The following is a description of a gene set: Expression of estrogen-related receptor alpha (ERRalpha) has recently been shown to carry negative prognostic significance in breast and ovarian cancers. The specific role of this orphan nuclear receptor in tumor growth and progression, however, is yet to be fully understood. The significant homology between estrogen receptor alpha (ERalpha) and ERRalpha initially suggested that these receptors may have similar transcriptional targets. Using the well-characterized ERalpha-positive MCF-7 breast cancer cell line, we sought to gain a genome-wide picture of ERalpha-ERRalpha cross-talk using an unbiased microarray approach. In addition to generating a host of novel ERRalpha target genes, this study yielded the surprising result that most ERRalpha-regulated genes are unrelated to estrogen signaling. The relatively small number of genes regulated by both ERalpha and ERRalpha led us to expand our study to the more aggressive and less clinically treatable ERalpha-negative class of breast cancers. In this setting, we found that ERRalpha expression is required for the basal level of expression of many known and novel ERRalpha target genes. Introduction of a small interfering RNA directed to ERRalpha into the highly aggressive breast carcinoma MDA-MB-231 cell line dramatically reduced the migratory potential of these cells. Although stable knockdown of ERRalpha expression in MDA-MB-231 cells had no effect on in vitro cell proliferation, a significant reduction of tumor growth rate was observed when these cells were implanted as xenografts. Our results confirm a role for ERRalpha in breast cancer growth and highlight it as a potential therapeutic target for estrogen receptor-negative breast cancer. from publication Stein RA, Chang CY, Kazmin DA, Way J, Schroeder T, Wergin M, Dewhirst MW, McDonnell DP (PMID 18974123) Human Gene Set: STEIN_ESRRA_TARGETS Genes regulated by ESRRA in MCF-7 cells (breast cancer). species: Homo sapiens, and this is the list of marker genes: MGST3, IDH3B, NPM3, RABIF, SOD2, SLC35F2, PLCXD1, DLD, RAP1GAP2 (NCBI Gene Id 388321), HPN, ATP5MG, CSNK1G2, ECI2, MRPS11, TCAF1, CTSC, CDC23, GMCL1, OXA1L, OSBPL1A, WWC1, PCTP, GFPT1, KIF3B, HTATIP2, PLEKHB2, NDUFA9, NDRG2, OGDH, NAGPA, TBX2 (NCBI Gene Id 6909), SUCLA2, RGP1, MIEF1, BDH2, MTX2, TIMM50, SULT2B1, TACC1, ATP2A3, KCNN4, RHOQ, MRPL4, RNF34, EXOSC2, DBNDD1, ASB6, SEC23B, RASA4, NDUFS1, GFPT2, UST, PPIC, ST3GAL4, CAV2, MAEA, RBM38, VPS26C, ANKRD28, TMEM184C, ACO2, IMMT, HMOX2, ABCB9, FRK, MFF, TRPC3, TNFRSF11B, MFN2, PRKAR2B, AURKA, PDHX, HLA-E, NANS, STN1, SMC2, RAB35, MINDY1, SLCO1A2, DGUOK, PXMP4, LEFTY1 (NCBI Gene Id 10637), H2BC10, UQCRFS1, PLA2G12A (phospholipase A2 group XIIA), TBC1D31, EFCAB14, FAM174B, QRSL1, COX7B, CYTH1, NPR3, NXF1, CCNG2, VWA8, ATP5MC1, EPAS1 (endothelial PAS domain protein 1), ACAA2, NDUFS2, SDHB, IFT27, PLPPR2, HIGD1A, EGLN1, CYCS, NOL6, PDSS1 (decaprenyl diphosphate synthase subunit 1), CASP9, GK, ETS2, KCNK13, DGAT1, CTSL, NDUFA8, MARCHF3, FAHD2A, SEPTIN8, ATP5PO, KIAA0040, DAXX, MARCKS (myristoylated alanine rich protein kinase C substrate), CKMT2, NDUFS8, ZNF302, CLDN3, TRAK2, FANCF, ST3GAL5, ACAT1, MYO19, EBP, CKMT1B, DHDDS, GRK4, DLAT, ZNF24, ACACB (NCBI Gene Id 32, acetyl-CoA carboxylase beta), NDUFS4, CYBC1, FOXD1, TMX4, FOXC1, KANK2, PLGRKT, VEGFA (NCBI Gene Id 7422), ATP5MC3, UGP2, SUCLG1, CKB, UQCRB, VDAC3, ADRA2C, CYP1B1 (cytochrome P450 family 1 subfamily B member 1), OPA1, MBD4, SLC25A12, IVNS1ABP, TRIM8, DCTPP1, CYP1A1, WDHD1, SIK1, AFG3L2, HOOK1, NDRG4, TGFBR2, COQ3, ADCY1, ECSIT, SAMM50, ATG2B, TRAM2, TCIRG1, INPP1, YIPF2 (Yip1 domain family member 2), PGM1 (NCBI Gene Id 5236), AHCYL1, ACYP1, TNFRSF10B, BMP7, HCCS, SNX24, CYP24A1, SCAMP5, SLC38A7, TUBD1, SLC46A3, RALA, FZD2, MTARC2, CA12, TOMM70, FDX1, STX18, BRD3OS, PCGF1 (polycomb group ring finger 1), EPN3, IMPA1, PATZ1, PPP2R2D, TMC6, SETMAR, PHB1, SOCS2, RGS19, ZHX3, ATP6V0E2, FSCN1, GOT2, ZNF669, TACO1, AHCYL2, ATP5MJ, INTS12, SLC10A2, CXCL12, SYNGR1, SLC25A20, CFLAR, VDR, FAM162A, THAP4, YJU2B, COX5B, FA2H, ZNF7, CAAP1, ATP5PF, RAP1GAP, B4GAT1, CD83, RBM7, ASPSCR1, MTRF1, AKAP1, PDCD10, TFE3, TRMT112, PRPSAP1, UQCRC2, FZD10, SSB, RNF139, APOO, SLC16A1 (NCBI Gene Id 6566), RAB21, UCK2, BRD3, JMJD6, LPCAT3, MMACHC, ZNF576, MYO6, TUBB6, SUPV3L1, DFFA, USP4, SPTLC2, RNF14, TIMM8A (NCBI Gene Id 84782), MRPS30, IQSEC1, GAS6, RAB17, STK26 (serine/threonine kinase 26), ST6GALNAC4, AIFM1, NDUFS3, CS, FDXR, ELP5, DUSP1, NSUN3, NQO2, HEXIM1, TMEM132A, ISCA1, GRPEL1, PAFAH2, GSTM1, ZBTB43, TRIM52, UTP25, ZNF750, SEC14L2, MRPS22, GDF15, MCF2L-AS1, HSPB8, RBM12B, AK1, IDH3A, RHBDF1, CEP70, RBFOX2, FAM50B, ATP5F1C, IER3, FGFR3, LIFR, MDH1, TIMM17A, ARID4A, CENPU, TACC2, MORC2, SPINT1, MED9, FBXL15, ZNF768, SMIM8, ZNF134, DNAJC11, SLC25A3 (NCBI Gene Id 5250), ZNF514, CCDC121, RHOF, NECAB3, CALU, CPT1A, MMUT, MXD4, DENND10P1, NR2F2 (nuclear receptor subfamily 2 group F member 2), TERF1, TNFAIP8, ANXA2P3, CIAPIN1 (NCBI Gene Id 57039), ATP1B1, MPC2, NFU1, HPF1, ASNS, SIGMAR1, ABCB7, OCLNP1, QARS1, RTL8C, SLC16A3, PEA15, UBAC1, MLYCD, CISD1, MAFB, COX10, CHCHD3, ORC2, SLC37A4, CLEC16A, MGST2, FASTKD1, PCYT2, MANF, DDIT3, PPP1R13L, P2RX5, DECR1, ARFRP1, PFKM, CAPRIN2, TRIM14, SMARCC1, TIGAR, NDUFB5, RFXANK, RNASET2, EPOR, MRPL2 (NCBI Gene Id 65007), BTG3, GPI, MCM4, CA2, ETFDH, MATK, STEAP3, TWF2, PPL, SIKE1, HK1, VDAC2, TEX2, NDUFS7, PLIN3, NUCB1, RETREG1, RPS6KA1, PDHA1, ULK1, GM2A, MMP9, GSTM4, GOT1, WIPI1, OTUB2, DCAF15, ARL2BP, ATXN3L, MPC1, NNT, ALDH3A2, ESRRA, SCML1, DUSP22, CYP27B1, CPTP, CRNKL1, LRRC41, NDUFAF4, ABLIM1, DHX40, STARD7, RAPGEF6, PRKD2, MAP1B, EMC3, MIPEP, GNPDA1, MRPS12, CLUH, SLC25A40, VANGL1, CMTR1 (NCBI Gene Id 23070), SYNGR3, ENDOG, EIF3K, YPEL5, MSH6, LAMB1, MITF, SLC25A4, C4orf19 (chromosome 4 open reading frame 19), SLC39A14, COA1, DLST, GATAD1, DCTD, RNF4, COX5A, EHHADH, TRPC1, ZNF165, SDHA, UAP1L1, LETMD1, CMC2, PMM1, PLS1, GABARAPL1 (NCBI Gene Id 23710), PPIF, MECR, SH2B1, SRPK2, NDUFA10, GSTK1, FH, ALDOC, BPTF, FEN1, PEX26, SEC14L1, SLC2A6, EGLN3, CLDN1, B4GALT5, AMPD3, ISOC2, VPS9D1, ILVBL, ISCU, ASPH, ZNF43, AP5M1, TTC33, SULT1A2, ECI1, UQCRC1, LIN37, TRIO, PRPS2 (phosphoribosyl pyrophosphate synthetase 2), SLC31A1, SIRT5, ZNF629, GTPBP8, ACADM, GTF2B, ACAA1, ALAS1, MRPL34, OPLAH, PLAU, SDHD, RNF5, ACADSB, ZNF45, PHF8, PHIP, IMPA2, OR7E14P, UBR7, CST6, COQ9, TMT1A, DSG2, SLC39A8, TMEM184B, NAP1L1, PFKP, GAS2L1, OPN3, SLK (NCBI Gene Id 9748), PDCL, PSG9 (NCBI Gene Id 91052), WDR45, MRPL35, PRSS22, MRPL11, NUDT3, MRPL15, CIZ1, AFF1, NDUFV1, TJP3, BOP1, DHRS11, TRIM2, ZNF44, MDH2, ACY1, ANXA6